Given this list of marker genes Gstt2, Gpx4, Ptges, Gstp3, Gsta13, Alox5ap, Gpx1, Ltc4s, Gstm7, Gsta5, Prdx6, Gpx7, Mgst2, Cp, Gpx6, Gstt1, Gstp1, Gpx2, Gstk1, Mgst3, Gpx5, Gsta2, Gpx3, Prdx6b, Gpx8, Gstp-ps, Gsta1, Mgst1, Gstp2, here is a description of the gene set: Mouse Gene Set: GOMF_GLUTATHIONE_PEROXIDASE_ACTIVITY Catalysis of the reaction: 2 glutathione + hydrogen peroxide = oxidized glutathione + 2 H2O. species: Mus musculus